The following is a description of a gene set: Human Gene Set: REACTOME_OLFACTORY_SIGNALING_PATHWAY species: Homo sapiens Olfactory Signaling Pathway, and this is the list of marker genes: OR8U3 (NCBI Gene Id 79485), OR10R2 (olfactory receptor family 10 subfamily R member 2), OR4C3, OR10Q1, OR6K6, OR6C68, OR2V2, OR1G1, OR10J5, OR2L8, OR6J1, OR2AE1, OR52B2, OR6F1, OR1N2, OR6C3, OR13C5, OR4N4, OR6A2, OR52B6, OR6V1, OR10Z1, OR4F16, OR10G8, OR6M1 (NCBI Gene Id 79548), OR10G7, OR2T10, OR5L2, OR51T1, OR5M1, OR5P3, OR2K2, OR1C1, OR10AC1, OR2AG2, OR2A12, OR14A16, OR5AC2, OR51F2, OR4F17, OR7A5, OR2T35, OR8K1, OR5D13, OR2A7, OR7G1, OR1Q1, GNG13, OR8H3, OR6C4, OR14A2 (NCBI Gene Id 81453), EBF1, OR11G2, OR9K2, OR2T8, OR12D3, OR2AP1, OR5AU1, OR5B21, CNGA4, OR5K1, OR52I1 (olfactory receptor family 52 subfamily I member 1), OR11H4, OR2AK2, OR5T1, OR8B2, OR4K15, OR4L1, OR5H2, OR4Q3, OR1A1, OR10P1, OR2M7, OR51Q1, OR4K5 (olfactory receptor family 4 subfamily K member 5), OR52E8, OR10A4, OR1B1, OR4C6, OR9G1, OR11H2, OR8J2, OR4D10, OR10G3, OR10C1, OR2T27, OR10K1, OR2H1, OR10H1, OR10J4 (olfactory receptor family 10 subfamily J member 4 (gene/pseudogene)), OR4M2, OR6C65, OR51J1, OR3A1, OR51G1, OR4F29, OR13A1, OR51V1, OR56A3, RTP2, OR4F15, OR2B6, OR6B2 (olfactory receptor family 6 subfamily B member 2), OR1D4, OR8U1, OR2M2, OR14J1, OR8K5, OR9G4 (NCBI Gene Id 81158), OR2B11, OR9Q2, OR5T2, OR2T29, OR5A2, OR10T2, OR13C8, OR51H1, OR2C3, OR2T34, OR13H1, OR52E2, OR5V1, OR2T6, OR2T1, OR4A5, OR51I2, OR5J2 (NCBI Gene Id 282775), OR4M1, OR4K1 (olfactory receptor family 4 subfamily K member 1), OR1M1, OR52E4, OR52A1, OR6C70, OR4A8, OR5B3, OR52H1, OR6B1, OR2B2, OR7G2, OR52E1, OR4E2, OR13C2, OR1I1, OR5T3, OR2Y1, OR10H5, OR56B4, OR8I2, OR52A5, OR52I2, OR2G6, OR7A17, OR4C5, OR13C4, OR1L4, OR51M1, OR4D11, OR2A42, OR8S1, OR9A2 (olfactory receptor family 9 subfamily A member 2), OR5P2, OR2C1, OR8D2, OR10A7, OR7D2, OR4N2, OR2Z1, OR2AG1, OR2L2, OR11L1, OR51G2, OR10A2, OR56A5, OR2V1, OR9Q1, OR8U9, OR11H6, OR4D2, OR1J4, OR14I1, OR2A1, OR2D2, OR2J1, OR1E1, OR2T3, OR5AN1, OR1N1, OR1E2, OR2J2, OR2T4, OR4D5 (olfactory receptor family 4 subfamily D member 5), OR51B4 (NCBI Gene Id 79339), OR8B3, OR52L1, CNGB1, OR10H4, OR2T5, OR1P1, OR5M9, OR51L1, OR6C2 (NCBI Gene Id 81045), OR5H1, OR2H2, OR1L1, OR6N2, OR4D1, OR2A25, OR10A6, OR10G4, OR8J3, OR52E5, OR5B12, OR10J3, OR2G3, OR9I1, OR1J2, OR5AC1, OR6Y1, OR51F1, CNGA2, ANO2, OR2L13, OR5G3 (olfactory receptor family 5 subfamily G member 3 (gene/pseudogene)), OR10G2, OR2T2, OR1S1, OR10S1, OR52K2, OR52E6, OR10G6, OR1D5, OR51E1, OR6B3, OR13J1 (NCBI Gene Id 81371), OR8G1, OR5AR1, OR1L3 (olfactory receptor family 1 subfamily L member 3), OR4F4, OR8G5, OR51B5, OR2G2, OR2M3, OR52N5, OR12D2, OR6Q1, OR7A10, OR4C13, OR7G3, ADCY3, OR1F12P, OR56A4, OR5AL1, OR6K2, OR2T11 (NCBI Gene Id 282743), OR5M11, OR6C76, OR10J1, OR8D4, OR51A4, OR1F1, OR5AS1, OR51B2, OR1L6, OR8A1, OR13D1, OR4X2, OR1J1, OR4P4, OR5D18, OR10G9, OR4S1, OR10AG1, OR10A3, OR52N1, OR2AT4, OR2D3, OR2S2 (NCBI Gene Id 56656), OR4F6, OR4A15, OR1E3, OR3A3, OR51S1, OR4D9, OR7C1, OR8B8, OR8J1 (olfactory receptor family 8 subfamily J member 1), OR11A1, OR11H1, OR4F5, OR4B1, OR51D1, OR4S2, LDB1, OR5M8, OR10AD1, OR3A2, OR14C36, OR5K2, GNB1, OR8H1, OR4D6, OR52N4, OR2W1, RTP1, OR2A2, OR8B12, OR1S2, OR5A1, OR10H3, OR5AP2, OR5B2, OR4A47, OR8D1, OR5B17, OR52M1, OR52N2, OR1D2, OR1A2, OR5W2, OR5H6, OR51E2, OR2A14, OR56A1, OR5H14, OR7C2, OR1K1, OR6C75, OR51A7, OR2M4, OR5M10, OR6X1, OR5H15, REEP1, OR52Z1P, OR52W1, OR5K3, OR5I1, OR7D4, OR10K2, OR5L1, OR13F1, OR5F1, OR6S1, OR13C9, OR2L3 (NCBI Gene Id 81468), OR52D1, OR13C3, OR52R1, OR4C16 (NCBI Gene Id 81308), OR9A4, OR1L8, OR4C12, OR4C46, OR6C1, OR6K3, OR2B3, OR4K3, LHX2, OR2A4, OR7E24, OR52J3, OR10X1, OR2T7, OR52K1, OR4K17, OR56B1, OR14K1, OR4K14, OR4Q2, OR9G9, OR51A2, OR5C1, OR4K13, OR2A5, OR8U8, OR10A5, OR4C15, OR2L5, OR4N5, OR6C74, OR5M3, OR4X1, OR4C45, OR4F3, OR2W3, OR2M5, OR4F21, OR8K3, OR51I1, OR8H2, OR2J3, OR2F2, OR4K2, OR6C6, OR5AK2, OR51B6, OR6T1, OR2T12, OR2F1, OR10W1, OR4E1, OR13G1, OR6N1, OR5D14, OR2AJ1, OR10D3, OR11H7, OR10H2, OR8B4, OR4C11, OR5D16, OR5K4, OR10V1, OR6P1, GNAL, OR4A16, OR2T33